The following is a description of a gene set: from publication Cui A, Huang T, Li S, Ma A, Pérez JL, Sander C, Keskin DB, Wu CJ, Fraenkel E, Hacohen N (PMID 38057668) Genes positively differentially expressed in cell type: cDC2 (conventional dendritic cell type 2) upon treatment with cytokine: IL-9 in mouse lymph nodes in vivo. Mouse Gene Set: CUI_CDC2_IL9_RESPONSE_UP studied in species Mus musculus Cytokines mediate cell-cell communication in the immune system and represent important therapeutic targets. A myriad of studies have highlighted their central role in immune function, yet we lack a global view of the cellular responses of each immune cell type to each cytokine. To address this gap, the authors created the Immune Dictionary, a compendium of single-cell transcriptomic profiles of more than 17 immune cell types in response to each of 86 cytokines (>1,400 cytokine-cell type combinations) in mouse lymph nodes in vivo. A cytokine-centric view of the dictionary revealed that most cytokines induce highly cell-type-specific responses. For example, the inflammatory cytokine interleukin-1β induces distinct gene programmes in almost every cell type. A cell-type-centric view of the dictionary identified more than 66 cytokine-driven cellular polarization states across immune cell types, including previously uncharacterized states such as an interleukin-18-induced polyfunctional natural killer cell state., and this is the list of marker genes: Fabp5 (fatty acid binding protein 5, epidermal), Efhd2, Tnip3, Sdc4 (NCBI Gene Id 99320), Ak2, Slc30a4